The following is a description of a gene set: Any process that modulates the frequency, rate or extent of an ATPase-coupled calcium transmembrane transporter activity. studied in species Mus musculus Mouse Gene Set: GOBP_REGULATION_OF_ATPASE_COUPLED_CALCIUM_TRANSMEMBRANE_TRANSPORTER_ACTIVITY, and this is the list of marker genes: Smim6, Mrln, Strit1, Hspa2, Sumo1, Tlr9, Atp2a1, Zfas1, Pln, Vmp1, 1810037I17Rik, Sln